The following is a description of a gene set: Human Gene Set: chr21p11 species: Homo sapiens, and this is the list of marker genes: MIR3648-2, SLC25A15P4, ENSG00000276289, ENSG00000278932, TEKT4P2, SNORA70, RN7SL52P, LINC03105, VN1R7P (NCBI Gene Id 54042), ENSG00000277277, ENSG00000310061, TPTE, LINC01666, IGHV1OR21-1, CDRT15P8 (CDRT15 pseudogene 8), ENSG00000280441, LINC01667, ENSG00000277067 (NCBI Gene Id 102724843), RNA5-8S4, RNA5-8SN3, CDRT15P9, SNX18P12, RNA5-8SN1, MIR6724-4, NCOR1P4, BAGE2, RNA5-8SN2, RPSAP68, SOWAHCP2, ENSG00000273590, MIR6724-2, ENSG00000278961, SNX18P10, CTBP2P10 (CTBP2 pseudogene 10), CTBP2P9, MIR6724-3, MIR3648-1, EIF3FP1, MIR6724-1 (NCBI Gene Id 102465433), MTCO1P1, CYCSP41